Given this list of marker genes Enpp1 (ectonucleotide pyrophosphatase/phosphodiesterase 1), Hgsnat, Ahcy, Hyal4, Cbs, Alpi, Nudt19, Mtrr, Blmh, Ggt1, Csad, Acot2, Hyal1, Ids, Abcd1, Hpse, Mat1a, Nudt7, Vnn1, Idua, Gns, Pank4, Ggt5, Fitm2, Acat1, Arsb, Cdo1, Acot7, Ggt7, Ahcyl, Sgsh, Gusb, Naglu, Chac1, Dpep1, Agxt, Hexb, Ctsl, Nudt8, Chac2, Mlycd (malonyl-CoA decarboxylase), Dpep2, Galns, Gpc1, here is a description of the gene set: The chemical reactions and pathways resulting in the breakdown of compounds that contain sulfur, such as the amino acids methionine and cysteine or the tripeptide glutathione. species: Mus musculus Mouse Gene Set: GOBP_SULFUR_COMPOUND_CATABOLIC_PROCESS